Given this list of marker genes JAK2, BCR, MPL, THPO, ABL1, here is a description of the gene set: A myeloproliferative disorder characterized by increased proliferation of the granulocytic cell line without the loss of their capacity to differentiate. Human Gene Set: HP_CHRONIC_MYELOGENOUS_LEUKEMIA species: Homo sapiens Chronic myelogenous leukemia